The following is a description of a gene set: The chemical reactions and pathways involving dicarboxylic acids, any organic acid containing three carboxyl (COOH) groups or anions (COO-). Human Gene Set: GOBP_TRICARBOXYLIC_ACID_METABOLIC_PROCESS studied in species Homo sapiens, and this is the list of marker genes: PCK1, IDH3G, ACO1, SLC34A1, ASS1, IDH2, SIRT4, ACO2, CS, IDH3A (NCBI Gene Id 3419), ACACB, GLUD1, IDH3B, IDH1, ACLY